Given this list of marker genes Prkce, Bax, Pmaip1, Slc25a27 (NCBI Gene Id 78577), Bnip3, Rnf122, Mtch2, Prelid1, Adcy10, Trpv1, Mapt, Pip5kl1, Bnip3l, Arl6ip5, here is a description of the gene set: species: Mus musculus Any process that stops, prevents, or reduces the frequency, rate or extent of establishment or extent of a mitochondrial membrane potential, the electric potential existing across any mitochondrial membrane arising from charges in the membrane itself and from the charges present in the media on either side of the membrane. Mouse Gene Set: GOBP_NEGATIVE_REGULATION_OF_MITOCHONDRIAL_MEMBRANE_POTENTIAL